The following is a description of a gene set: studied in species Homo sapiens Canonical and non-canonical Notch signaling Human Gene Set: WP_CANONICAL_AND_NONCANONICAL_NOTCH_SIGNALING, and this is the list of marker genes: RRAS, MAML1, DLK1, JAG1, NOTCH2, DLK2 (NCBI Gene Id 65989), PSEN1, DLL1, MAML2, MFAP2, DNER, NOTCH3, MFAP1, NOTCH4, CNTN6, ADAM10, RBPJ, LEF1, JAG2, HES1, CHUK, NOTCH1, DLL4, MAML3, HEY1, PSEN2, DLL3